Given this list of marker genes Ptpra, Itga9, Adam15, Vav1, Madcam1, Tyrobp (TYRO protein tyrosine kinase binding protein), Ptk2, Plek, Fcer1g, Lama5, Mpig6b, Plpp3, Itgb7, Tln1, Src, Itga4 (NCBI Gene Id 16401), Itga6, Itgae, Lypd10, Pxn, Bcar1, Itgb3, Lamb1, Chuk, Itga8, Cd177 (CD177 antigen), Apoa1, Itgb1bp1, Pcsk5, Sema7a, Fermt2, Diaph3, Itga5, Fermt3, Ilk, Lims1, Ptpn11, Tspan32, Lamc1, Itgb5, Vtn, Ctnna1, Itga2b, Itgb4, Nme2, Itga10, Itgbl1, Itga7, Rhoa, Fgr, Ptn, Dab2, Itgax, Cdh17, Itgal, Fyb2, Fut8, Itga1, Itgam, Ikbkb, Ccn2, Cd40lg, Nrp1, Ptk2b, Gab2, Itgad, Itgb6, Zyx, Tec, Rcc2, Itga3, Lama1, Abl1, Lama2, Cd63, Slc2a10, Pram1, Itgb8, Flna, Lat (linker for activation of T cells, NCBI Gene Id 16797), Fermt1, Col3a1, Itgb2, Syk, Itgav, Arhgap35, Lamb2, Loxl3, Thy1, Lims2, Itgb1, Vav3, Cul3, Mapk8, Itgb2l, Emp2, Itga11, Itga2, Fn1, Phactr4, Nid1, Fyb1, Cdc42, Isg15, Timp1, Lypd11, here is a description of the gene set: studied in species Mus musculus Mouse Gene Set: GOBP_INTEGRIN_MEDIATED_SIGNALING_PATHWAY The series of molecular signals initiated by an extracellular ligand binding to an integrin on the surface of a target cell, and ending with the regulation of a downstream cellular process, e.g. transcription.